The following is a description of a gene set: Reactome Pathway: Vitamin B5 (pantothenate) metabolism species: Homo sapiens Vitamin B5 ((R)-pantothenate, PanK), is an essential precursor for the synthesis of the metabolic cofactor Coenzyme A (CoA-SH) and is the prosthetic group of acyl carrier protein (ACP). The name pantothenate is from the Greek “pantothen”, "from everywhere". Both pantothenate and CoA-SH are found in nearly every foodstuff and in the gut microbiome. CoA-SH itself is readily degraded in the gut and in extracellular fluids within the body. No processes are known to transport it across plasma membranes. Instead, individual cells take up PanK, which is stable in the extracellular environment, to synthesize CoA-SH for their own use. Within a cell, distinct groups of CoA-SH-requiring reactions occur in the cytosol, mitochondrial matrix, and peroxisomes, and controlling CoA pool size in each location plays a major role in regulating and integrating cellular metabolic processes. Control is achieved by selective degradation, synthesis, and transport of CoA within a cell. The reactions annotated here provide an incomplete description of these processes, as key steps remain incompletely understood. part of: Metabolism of water-soluble vitamins and cofactors, and this is the list of marker genes: PANK2, NUDT8, PPCDC, DCAKD, VNN2, ENPP1, SLC25A42, AASDHPPT, ENPP3, PANK3, SLC5A6, COASY, ENPP2, PANK4, PDZD11, VNN1, PPCS, FASN, PANK1, SLC25A16